The following is a description of a gene set: The presence of abnormal electromyographic patterns indicative of myopathy, such as small-short polyphasic motor unit potentials. species: Homo sapiens Human Gene Set: HP_EMG_MYOPATHIC_ABNORMALITIES EMG: myopathic abnormalities, and this is the list of marker genes: PHKG1, COL12A1, CASQ1, ALDOA, MUSK, SVIL, CHAT, POMT1, GAS1, GIPC1, DES, SHH (sonic hedgehog signaling molecule), TRIP4, LMNA, LRP12, TRIM32, SYNE2, VWA1, SGCG, PLEC, MYF6, SUFU, DUX4, GNE, RAPSN, PHKA1, SCO2, SMCHD1, MYH7, KLHL41, BAG3, SYNE1, SGCA, AK9, CRPPA, MYH14, KLHL9, MYPN, TGIF1, ZIC2, FKRP, DHX16, ANO5, ORAI1, CDON, MYOT, COL13A1, PTCH1, FLNC, HNRNPA1, CHCHD10, SCN4A, BIN1, TWNK, FKTN, SNUPN, VAMP1, SLC25A4, DYSF, FXR1, RYR1, ACAD9, CHRNA1, AGRN, UNC45B, GYG1, ABHD5, SLC5A7, NALCN, TNNT1, SNAP25, VCP, FHL1, SLC25A1, TPM3, TTN, SLC18A3, RILPL1, SQSTM1, STIM1, LAMP2, ADSS1, COL6A1, TANGO2, RRM2B, LDB3, FRG1, TK2, DNAJB4, CLCN1, DISP1 (NCBI Gene Id 84976), POLG2, CRIPTO, FOXH1, TMEM43, UNC80, CHRND, SYT2, DNMT3B, TPM2, MEGF10 (multiple EGF like domains 10), LARGE1, EMD, COL6A3 (collagen type VI alpha 3 chain), HNRNPA2B1, GLI2, DUX4L1, SAR1B, NEFL, COL6A2, MYBPC1, MTMR14, ACTA1, POLG, KBTBD13, MSTO1, MYO9A, DNM2, CHRNE, NEB, TIA1, CHRNB1, FGF8, MPV17, JAG2, CAV3, DLL1, PLOD1, NODAL, LRP4, FGFR1, TNPO3, SIX3, CRYAB, DOK7